The following is a description of a gene set: species: Homo sapiens Analysis of the transcriptional response to SARS-CoV-2 compared with other respiratory viruses, including MERS-CoV, SARS-CoV-1 (SARS), human parainfluenza virus 3 (HPIV3), respiratory syncytial virus (RSV), and IAV. Genes up-regulated in SARS-CoV-2 infection with Ruxolitinib (ACE2 expressing A549 cells, MOI: 2, 24hpi) Human Gene Set: BLANCO_MELO_COVID19_SARS_COV_2_INFECTION_A594_ACE2_EXPRESSING_CELLS_RUXOLITINIB_UP from publication Blanco-Melo D, Nilsson-Payant BE, Liu WC, Uhl S, Hoagland D, Møller R, Jordan TX, Oishi K, Panis M, Sachs D, Wang TT, Schwartz RE, Lim JK, Albrecht RA, tenOever BR (PMID 32416070), and this is the list of marker genes: TET3, SNORA31, ZNF26, CCDC85A, IKZF5, PER3, HS3ST3B1, MXD1 (MAX dimerization protein 1), LINC02995, C12orf50, SNORA3A, GCNA, KDM7A-DT, LPA, PIM1, SEMA4A, PPP1R15B, LIF, PER2 (NCBI Gene Id 8864), FGF12, ANKRD12, ZNF432, CCNP, WRAP53, H2AC13, RBM39, SALL1 (NCBI Gene Id 6299), ZNF8, ZNF484, EPM2AIP1, B3GNT5, BCL2A1, SLC6A12, MIR561, PPTC7, ZNF764, PLD6, TNF, ZEB1-AS1, ALPK3, BDKRB2, CDK5R1, NPTX1, PROM1 (prominin 1), SERTAD2, TEX29, KLK14, LINC00926 (NCBI Gene Id 283663), ZNF554, CXCL2, NEDD4L, NR4A3, RBAK, SKIL, ILF3-DT, INO80D, SNIP1, CCDC144CP, ABL2, PAN3-AS1, TANK, GEM, ZBTB6 (zinc finger and BTB domain containing 6), ELL, APRG1, NBPF10, H2AC15, CSRNP1 (cysteine and serine rich nuclear protein 1), GAS2L3, GPCPD1, IFNA22P (interferon alpha 22, pseudogene), EREG (NCBI Gene Id 2069), MIR4453HG, HLA-F-AS1, CYP27A1, ZNF296, ZNF211, ADAM8, ZNF821, KCNN1, H2BC21, ZNF300P1, MIR497HG, ZNF639, IL20RB, SERTAD3, NFKB1, CLUHP3 (NCBI Gene Id 79014), NFIL3, CSKMT, RNF6, TBC1D22B, NFYC-AS1, FOXC2, HIVEP2, SCARNA15, CREB5, SERPINC1, PYGM, ADAM20P1, VXN, CCL2, NRIP1, PRKXP1, AGAP6, P2RX5-TAX1BP3, SPOCK2, CELF1, CDKL3, KLF7, UBASH3A, TAF1D, GUCA1B, FOSL1, ZNF830, ESF1, H2BC18, COLEC11, ADM, MUC6, ZNF143-AS1, FLCN, EXPH5, GZF1, SNORA3B (NCBI Gene Id 677826), LINC00472, ZNF280B, ZNF34, ZNF776, LCDR, COL2A1, ADM5, KLHL3, DNAH17 (NCBI Gene Id 8632), RPS6KL1, KLF10, TBC1D15 (NCBI Gene Id 64786), NPC1L1, LTB, RSBN1, MEX3C, PCF11, RLIM, ZNF44, CXCL3 (C-X-C motif chemokine ligand 3), FOXN2, SLC16A14 (NCBI Gene Id 151473), IER2, N4BP3, INTS6, SNORA48, ZBTB43, NECAP1, DCHS1 (dachsous cadherin-related 1), THAP1, SNORA62, SNORA8, ATP6V1G2, PLEKHG2, MRNIP, FRS2, TET2, LDLRAD4, LILRA6, SLC17A8 (solute carrier family 17 member 8), C3orf38, GPR3, H2BC20P, PTX3, MASP2, MED30, CD83, HYCC2, NFKBIZ, ARL5B, PPP1R10, CCL20, IFFO1, EFNA3, ZNF805, TLR10, CHP1P2, TBX4, TNFRSF10B-AS1, CCDC81, ETV3, ZC3H12A, ZNF143, ZNF317, RBBP6, IER5, DNAH2, CFL1P1, SNHG10, KLF4, HBP1, SPMIP1, DBP, CHIC2, PHF21B, MXD3, RRN3P1, STON1, MYSM1, ARL14, POU2F2, AOC2 (amine oxidase copper containing 2), PRR14, NFKBIA, RNASEK, PPP1R15A, ADAM32, HIVEP1, SMARCA4, MIR3685, AOC3, FBXW7, RELB, UBXN7, KLKP1, ZEB2, NHLH1, IRF4, SNORA25, KDM6B, NPHS1, NOCT, BACH2, EML2-AS1, ENSG00000284691, IKZF3, CXCL1, DDIT3, PMS2P3 (NCBI Gene Id 5387), CLK4, CCNT2, PCK1, SNHG20, HSF2, SLA, ZNF77, OTUD3, LINC01881, ODC1, IFNB1, CRY1, HDAC9, AURKAP1, KLF6, ESR1, SLC26A3, SIM2, EGR1, CCDC73, ZNF674-AS1 (ZNF674 antisense RNA 1 (head to head)), LINC00115, EPC1, MIER3, ANKRD49, CARINH, NAV2, ATF3, CARD9, NOD2, ARHGAP19, ZNF615, MPIG6B, MBIP, KDM7A, ZNF184, LOX, SRFBP1, CCDC116, SUMO4, KLF11, H4C5, TSSK3, PER1, MDM4, RAB2B (RAB2B, member RAS oncogene family), CFP, DIRAS1, SIX4, RASSF5, NSRP1, MIR23AHG, PNN, BCL3, ZNF567, ARC, GTF2B, TAF7L, ZNF614, H3C6, PLK1, ATF4 (activating transcription factor 4), NFKBID, CYLD, IPCEF1, MIR221, GPM6B, IER3, DUSP10, LSMEM1, ICAM5 (intercellular adhesion molecule 5), WTAP, LAMTOR3, CENPA, SUGT1P1, MB21D2, ARID3B, KMT2E, AEN, CCR6, ZNF799, STX11 (syntaxin 11), KMT2E-AS1, ESRRB, HOXC10, HYMAI, ALOXE3, ABTB2, ZNF557, BIRC3, EFNA1, LDHAL6B, NRG4, SCG2, ZNG1F, PRX, N4BP2L2-IT2, ZNF778, TIGD3, GRHL1, GOLGA7B, BIRC2, CDKN1B, IRAK2, CXCL8, LINC01089, VAMP2, C11orf91, ZNF627, TNFAIP8, NEURL3, ADNP2, ZFP36, MIER1, KCNQ4, KPNA5, NFKBIE, ZNF112, KCNAB3, OASL, SLCO5A1, ZUP1, NTNG2, SNHG1, RBM48, PDGFB, TRAF1, HCFC2, ZNF624, ARID4B, H2BC6, MKRN3, TIPARP, SNORD50B, ZNF222, HAVCR2, ZNF101, CCDC174, RFPL3S (NCBI Gene Id 10737), SNORD10, RIMOC1, BHLHE41, MED26, FOS, NR1D1, ZBTB10, CCNL1, SERPINA10, TTC21A, USPL1, SCUBE2, TNFAIP3, MIR7-1, ZNF543, OVGP1, CEP85L (NCBI Gene Id 387119), DRD1 (NCBI Gene Id 1812), BTG2, ZSCAN12P1, RSF1, FGF18, CLEC4A, NGFR, HLA-F, MAFG, CHD1-DT, SOX9, CD200R1, PROX1, B3GALNT2, KRTAP5-1, ZBTB20, H4C9, RAB33B, BTG1, GDF15, LINC-PINT, IL1A, MTSS1, HES1, BCL10, GADD45A, CCDC144BP, REL, USP43, HNRNPU, GOLGA6C, ZNF436-AS1, GNRH1, FILIP1L, SNORD28, ZNF14, DNAJC27, DCAF4L1, ARHGAP40, CIART, MIR5047, CRTC2, BMF, IL11, ZNF267, CHD2, ZC3H12B, IRF1 (NCBI Gene Id 96501), ZNF669, ZBTB21, ZBTB49, ZNF160, EBLN2, TMCC2, PTBP2, CAVIN4, CCNT1, SNORD38B, PIGR, ZNF555, FERMT3, ADIRF, PSMD6-AS2, FTH1P3, LGALS9 (NCBI Gene Id 90793), FOSB, ANKRD33B, SMNDC1 (survival motor neuron domain containing 1), RAB30, CNIH2, H1-3 (NCBI Gene Id 3007), MYNN, PPP4R1L, ALDH8A1, AEBP2, CCDC13, ZC3H4, H2AC25, TNFRSF9, MARCKS, CREBRF, CDKN2AIP, SELE, NFKB2, LRP2BP, PPP4R4, JUN, ATP2A1, MAFF, ACTG1P20, ARHGAP30, CHASERR, DCP1A, SENP7